The following is a description of a gene set: from publication Chen Y, Wang X (PMID 31504780) Genes predicted to be targets of miRBase v22 microRNA mmu_miR_30b_3p in miRDB v6.0 with MirTarget v4 prediction scores > 80 (high confidence targets). species: Mus musculus Mouse Gene Set: MIR_30B_3P, and this is the list of marker genes: Col5a2, Trex2, Scara5, Gpatch11, Srsf1, Cpsf6 (NCBI Gene Id 66698), 9330159F19Rik, Mospd2, Saa3, Hapln1, Gid4, Timp3, Sytl5, Xcr1, Asic1, Nlgn1, Gprc5a, Efna5, Tfap2b (NCBI Gene Id 98405), Peak1, Map3k8, Nav1, Zswim9, Calcoco1 (calcium binding and coiled coil domain 1), Vmn1r63, Atp2b1, Rnf185, Ranbp10, Mrgprd, Oas2, Gnai1, Rps6kb1, Spc25, Ppat, Aplp1, Tex2, Sgms2, Alpl, Il1r1, Ftcd, Trp53bp1, Rgs9, Cplx2, Mogs, Snap25, Tent4b